Given this list of marker genes LGR6, RPS10, CEP104, RPS3, EOMES, SCRN1, RPL8, ALDH16A1, ABCB1, IL16, ANKH, PRSS23, THEM4, BBX, WDR73, PABPC4, KIAA1671, UQCRB, DBP, ZNF641, CD244, BBS4, NOP53 (NOP53 ribosome biogenesis factor), ZNF264, TBC1D10C, NONO, C1orf21, SFN, ZHX2, GSE1, GNLY, CLIC3, TAF3, HIF1AN, ALDH1A1, MAPK1, FCRL3, EEF1G, PRR5L, RPL35, MBP, HTATSF1, RPS23, TMED4, KLRK1, FBL, MPHOSPH8, TGS1, PTGDR2, TMEM134 (NCBI Gene Id 80194), NR3C2, ACO1, PPP1R3E, ARHGAP9, HIPK2, POTEKP, ZNF577, SLAMF6, S1PR5, RPL30, AGO1, PTDSS1, UBA52, BACE2, IL2RB, IL18BP, ST13, BNC2, MRC1, UVSSA, PPTC7, PRF1, CPA3, YY1, EIF3L, AKR1C3, UBN1, RADX, BPNT2 (NCBI Gene Id 54928), LILRA4, RPL4, P2RY8, SYNE1, SBK1, MXD4 (NCBI Gene Id 10608), NRCAM, MAST3, SFI1, SELENOM, EPRS1, KIF21A, CNNM3, SPON2, RNPC3, CCR3, RPL36A, SUN2, TRIM27, ZMYND11, PIAS1, AKT3, RPS28, THAP12, NELL2, SNRNP70, ADGRE3, TULP4, LINC00921, VPS51, KIR2DL3, CEP126 (centrosomal protein 126), AMIGO1, RGS19, ABHD17A, ITGB7, DENND11, RPL21, LTBP3, TSEN54, TRIR (NCBI Gene Id 79002), GLG1, ZNF169, DRG2, HDC, UBE2Z, TRIM28, SPN, TIGIT, EIF4B, RPS18 (ribosomal protein S18), ABHD15, TUFM, MEAF6, MIR101-1, ZNF785, LMO7, RPL3, FCER1A, TGFBR3, RPL27, COMMD6 (COMM domain containing 6), IL7, ARHGAP30, ADGRG1, RTN1, SGPP1, NUMA1, AKR1B1, FGFBP2, LPXN, THAP11, CTSZ, RPL19 (NCBI Gene Id 6143), YPEL1, TMEM273, RACK1, NCOA3, NACA, CBX7, PLEKHF1, RPL18, DCANP1, LINC00996, LRP8, PTPN4, MYBL1, RPL10, ADRB2, CIITA, CLEC4C, ARAP1, AKAP12, FAM43A, VRK3, TTC31, FBXL17, HLA-DPB1 (major histocompatibility complex, class II, DP beta 1), SRGAP2, GOSR2, CD160, UICLM, FZD3, RFTN1, KLRB1, ZAP70, CLSTN1, KIF3A, PTGDR, SH2D1B, KLRD1, STMN3, NCALD, MBD4, here is a description of the gene set: studied in species Homo sapiens To study the transcriptional profile of patients with acute RSV or Influenza infection,children of median age 2.4 months (range 1.5-8.6) hospitalized with acute RSV and influenza virus infection were offered study enrollment after microbiologic confirmation of the diagnosis. Blood samples were collected from them within 42-72 hours of hospitalization. We excluded children with suspected or proven polymicrobial infections, with underlying chronic medical conditions (i.e congenital heart disease, renal insufficiency), with immunodeficiency, or those who received systemic steroids or other immunomodulatory therapies. The RSV cohort consisted of 51 patients with median age of 2 months (range 1.5-3.9) and the influenza cohort had 28 patients with median age of 5.5 months (range 1.4-21). Control samples were obtained from healthy children undergoing elective surgical procedures or at outpatient clinic visits. To exclude viral co-infections we performed nasopharyngeal viral cultures of all subjects. We recruited 10 control patients for the RSV cohort with median age of 6.7 months (range 5-10), and 12 control patients for the influenza cohort with median age of18.5 months (range 10.5-26). from publication Ioannidis I, McNally B, Willette M, Peeples ME, Chaussabel D, Durbin JE, Ramilo O, Mejias A, Flaño E (PMID 22398282) Genes up-regulated in comparison of peripheral blood mononuclear cells (PBMC) from healthy donors versus PBMCs from infanct with acute RSV infection. Human Gene Set: GSE34205_HEALTHY_VS_RSV_INF_INFANT_PBMC_UP